Given this list of marker genes Meiob, Trex1, Pole, Usb1, Exosc3, Mre11a, Trir, Isg20l2, Parn, Ddx1, Fen1, Wrn, Aen, Dis3l2 (NCBI Gene Id 77551), Exo5 (NCBI Gene Id 73172), Trex2, Apex2, Rad9a, Rexo4 (NCBI Gene Id 277501), Xrn1, Dclre1b, Polrmt, Nme5, Helz2, Exosc10, Cnot6l, Dclre1a, Cpsf3, Enpp3 (NCBI Gene Id 432441), Fan1, Pld4, Nme7, Noct, Rexo5, Alkbh3, Cnot2, Pold1, Dclre1c, Toe1, Pnpt1, Tdp1, Eri1 (exoribonuclease 1), Tatdn1, Rexo2, Isg20, Cnot7, Exd1, Enpp1, Aplf, Alkbh2, Enpp2, Dis3, Polg, Dxo, Xrn2, Aptx, Dcp2, Nme8, Exog, Rexo1, Rad1, Zc3h12a, Pde12, Cnot1, Dis3l, Rad50, Exo1, Pan2, Apex1, Exd2 (NCBI Gene Id 97827), Pan3, Myg1, Pnldc1, Pld3, Eri2, Eri3, Cnot6, Cnot8, Nme1, Mgme1, here is a description of the gene set: Mouse Gene Set: GOMF_EXONUCLEASE_ACTIVITY species: Mus musculus Catalysis of the hydrolysis of ester linkages within nucleic acids by removing nucleotide residues from the 3' or 5' end.